The following is a description of a gene set: studied in species Homo sapiens A separation of the layers within the wall of the descending aorta. Tears in the intimal layer result in the propagation of dissection (proximally or distally) secondary to blood entering the intima-media space. Descending aortic dissection Human Gene Set: HP_DESCENDING_AORTIC_DISSECTION, and this is the list of marker genes: EMILIN1, PRKG1, TGFBR1, MAT2A, TGFB2, MYLK, TGFB3 (NCBI Gene Id 7043), THSD4, ELN, SMAD2, MFAP5, ACTA2, MYH11, FOXE3, LOX, SMAD3, COL3A1, SMAD4, TGFBR2, FBN1 (NCBI Gene Id 7470), HEY2